The following is a description of a gene set: Mouse Gene Set: SARTIPY_BLUNTED_BY_INSULIN_RESISTANCE_UP We have employed microarray technology using RNA from normal 3T3-L1 adipocytes and from 3T3-L1 adipocytes made insulin-resistant by treatment with tumor necrosis factor-alpha to identify a new class of insulin-responsive genes. These genes continued to respond normally to insulin even though the adipocytes themselves were metabolically insulin-resistant, i.e. they displayed a significantly decreased rate of insulin-stimulated glucose uptake. Approximately genes/expressed sequence tags (ESTs) were screened. Of these, genes/ESTs were identified that became insulin-resistant as expected (e.g. Socs-3, junB, and matrix metalloproteinase-11). However, genes/ESTs continued to respond normally to insulin. Although some of these genes were previously shown to be regulated by insulin (e.g. Glut-1 and beta3-adrenergic receptor), other novel insulin-sensitive genes were also identified (e.g. Egr-1, epiregulin, Fra-1, and ABCA1). Real-time reverse transcription-PCR analysis confirmed the expression patterns of several of the differentially expressed genes. One gene that remained insulin-sensitive in the insulin-resistant adipocytes is the transcription factor Egr-1. Using an antisense strategy, we show that tissue factor and macrophage colony-stimulating factor, two cardiovascular risk factors, are downstream EGR-1 target genes in the adipocyte. Taken together, these data support the hypothesis that some signaling pathways remain insulin-sensitive in metabolically insulin-resistant adipocytes. These pathways may promote abnormal gene expression in hyperinsulinemic states like obesity and type II diabetes and thus may contribute to pathologies associated with these conditions. from publication Sartipy P, Loskutoff DJ (PMID 14530283) Genes up-regulated in 3T3-L1 cells (adipocyte) by insulin but displayed blunted response to insulin the insulin resistant cells. species: Mus musculus, and this is the list of marker genes: Nfil3, Mt2, Lrrfip1, Phb2, Cxcl1, Ifi211, Socs3, Rgl1, Frmd6, Junb, Nab2, Pprc1, Skil, Ccdc86, Sntb2, Ak4, Pkd2, Serpine1